The following is a description of a gene set: studied in species Mus musculus Mouse Gene Set: GOBP_CONNECTIVE_TISSUE_REPLACEMENT_INVOLVED_IN_INFLAMMATORY_RESPONSE_WOUND_HEALING The series of events leading to growth of connective tissue when loss of tissues that are incapable of regeneration occurs, or when fibrinous exudate cannot be adequately cleared, as part of an inflammatory response., and this is the list of marker genes: Lrrc25, Pparg, Clec10a, Il1a, F2r, Timp1, Hif1a